The following is a description of a gene set: Genes containing one or more binding sites for (H1_6) in their promoter regions (TSS -1000,+100 bp) as identified by GTRD version 20.06 ChIP-seq harmonization. studied in species Mus musculus from publication Yevshin I, Sharipov R, Kolmykov S, Kondrakhin Y, Kolpakov F (PMID 30445619) Mouse Gene Set: H1_6_TARGET_GENES, and this is the list of marker genes: Map3k14, Ehmt2, Ccpg1, Taco1 (NCBI Gene Id 70207), Abce1, Gnpat, Ptpn6, Cfap20, Fosb, Cnrip1, Mir1903, Smg8 (SMG8 nonsense mediated mRNA decay factor), Arl5c, Acsf2, Rundc1, Gm11788 (NCBI Gene Id 102640850), Mrpl45, Rnf222, Rapgef6, Prdx2, Acvrl1, Ptges3l (NCBI Gene Id 73635), Fa2h, Ttc1, Slc9a5, Ap2a1, Sumo2, Tex19.1, Gm11762, Gm13135, Nrp1, Crtc2, 1700051A21Rik, Hic1, Tmem235, Pitpnc1, Lsm4, Rpf1, Rnaseh2a, Irf1, Zfp276, Gcdh, Hus1, Arhgap27, Pgap1, Nr1d1, Hrob, Car5a, Nipal4 (NCBI Gene Id 214112), Aars1, Mrpl32, Esrp2, Rnf135, Mri1, Dnajc1, 4930544D05Rik, Ykt6, Fasn, Itgb4, Prpf19, Zfp750, Cntd1, Vps9d1, Pus10, Cebpz, Fdxr, Matn3, Mvd, Plekhh3, Pex13, 4921524J17Rik, Eral1, Sugp2 (SURP and G patch domain containing 2), Kdm2b, Gm11633, Tnip1, Erlin2, Sema4a, Nudt21, Coa3, Akap1, Psma2 (proteasome subunit alpha 2), Dmtn, Gm10614, Mettl16, A230056P14Rik, Rps12-ps9, Prmt7, Cntnap1, Sox15, Lurap1, Tspoap1, Ogfod1, Crispld2, Nptx1, Capn1, Atxn7l3, Dusp26, Nipa2, Pierce2, Ubl7, Map3k7cl, Ap1g1 (NCBI Gene Id 52301), Aatk (apoptosis-associated tyrosine kinase), Cep131, Xrcc2, Pmpcb, Ap2s1, Chct1, Cers1, Tradd, Rad54l2, Bcl10, Elp5, Cfdp1, Limk2 (NCBI Gene Id 97744), Piezo1, Sirt7, Zcchc10, Ndufaf7, Stac2, Fam161b, Polm, Gins2, Taco1os, Mllt1, Zfp1, Tubd1, Rps6kb1, Cd34, Zap70, Mir6936, Gtf2b, Dcp1a, Unk, Glra1, Anapc10, Cpsf1, Mfsd10, Epha2, Trmo, Fam222b, Car4, Mgat5b (mannoside acetylglucosaminyltransferase 5, isoenzyme B), 1700030K09Rik, Arhgef19, Slc43a2, Oxct1as, Fbxl8, Cdkl2, Dhx16, Gm13034, Ube2d-ps, Tmem97, Rbm34 (NCBI Gene Id 67649), Lkaaear1, Foxj1, Pfas, Calr3